The following is a description of a gene set: Any process that activates or increases the frequency, rate or extent of the chemical reactions and pathways involving fatty acids. studied in species Homo sapiens Human Gene Set: GOBP_POSITIVE_REGULATION_OF_FATTY_ACID_METABOLIC_PROCESS, and this is the list of marker genes: KLHL25, KAT2B, ELOVL5, MTLN, MLXIPL, AVP, PLAA (phospholipase A2 activating protein), MID1IP1 (NCBI Gene Id 58526), IRS1, PLIN5, ADIPOQ, APOC2, CD74, APOA5, SIRT2, GDF15, NR1H3 (NCBI Gene Id 113429), PPARA, AKT2, AVPR1A, MIR182, NR1H2 (nuclear receptor subfamily 1 group H member 2), ABCD1, PPARD, IL1B, PTGS2, PPARG, GPIHBP1, MLYCD, MIR96, ABCD2, APOA4, LPGAT1, SLC45A3, IRS2, CPT1A, PLA2G3, TWIST1, PPARGC1A, GHSR